The following is a description of a gene set: Human Gene Set: HEB_Q6 Genes having at least one occurrence of the motif RCCWGCTG in the regions spanning 4 kb centered on their transcription starting sites. This matches the TCF12 transcription factor binding site V$HEB_Q6 (v7.4 TRANSFAC). species: Homo sapiens, and this is the list of marker genes: USP2, RTN3, COLEC12, RGS7, WNT6, CCDC26, NUDT18, DVL3, BTF3P11, SPMIP5, MRPL54, IMPG1, FBRS, MYO18A, SLC1A4, ZP1, MYH3 (myosin heavy chain 3), PRRG2, ALK, XCL2, CARMIL3, CDK5R2, RASSF8, LMOD1, TBX6, HOOK1, ACVR1, H3C3, KDM2A, TMEM184A, ACTB, HMGN2, SH3BP1, EFNA1, S100A8, RUNX1T1, GPR37L1, CNTN2, GFI1, XPNPEP1, H2BC7, AAK1, TGFB2, PGF, SPECC1, GAS7, NTNG2, ZSWIM8 (zinc finger SWIM-type containing 8), WNT2B, CYTH3, CDC42SE1 (CDC42 small effector 1), MAPK4, RIPOR1, DAAM1, SRP54, FMO5, HOXA3 (NCBI Gene Id 3200), WDR81, SMAD7, OR10J1, SYTL2, RARA, PSD, FNDC5, TRIM8, FBXL20, CACNB3, APBA3, GADD45G, VSTM2A, GRIN2B, DTX1, ARHGEF5, FBXO5, ITSN1, TSC22D4, RNF121, SLC30A1, PLXNB3, KLHDC8A, CMKLR2, ZNF593, MUSK, RTKN, PDZK1, YTHDF2, ELN, KCNH3, KCNS3 (NCBI Gene Id 3790), TNS1 (NCBI Gene Id 7145), AGBL5, CREB3L1, TMOD4, RCOR2, GABPB2, ADAMTS8, KCNJ2, TGFB3, GNB3, ITGB1BP2, L1CAM, ZNF646, MLLT11, CCDC65, FAM98A, SORBS1, ANGPTL2, PTPN7, CYP2F1, MOB3C, KCNH2, RIN1, EPN3, TRAF4, NFE2L1, VEGFA, KNCN, KIRREL2, ADGRB3, CBFA2T2, PAX1, CADPS, CLVS1, DHRS3, PRKAG1, TMEM255A, NANOS1, ACTG2, ANXA8, GPR62, PMP22, KLF13, TNNT2, GPD1, HOXC12, TLNRD1, IL34, H3C4, MED13, SUMO2, C1orf210, ANGEL1, RPL4, RUFY1, TBC1D10B, ZNF668, CCND2 (cyclin D2), PRR30, NR5A1, TRIP4, SRPX, NDST4, S100A2 (S100 calcium binding protein A2), PDGFB, CHID1, RBMS3, SPOCK2, ATXN7L2, H2BC3, RXRG, RASL12, POLL, TUBA4A, KLK13, SEMA7A, SEZ6, MIR137HG, UBTF, MEN1 (NCBI Gene Id 4221), PRMT6, BCL6, RAB3A, MIR22HG (MIR22 host gene), GRIK3, TPPP3, ASTN1, KLHL10, MKNK2, BRD4, MRGPRF, ERBB3, CATSPER2, RNF111, PSME3, COL16A1, PDK2, ZNF362, NOSIP, SUV39H2, GATA3, HOXC4 (homeobox C4), CSMD3, MIR9-1HG, FAAP100, TLE3, SYNC, RASGEF1A, INKA1, EN1, BAZ2A, SPMIP8, INF2, GPR162, DOK3, LINC01089, ZRANB1, KCNMB3, TRIM46, RAB1B, UBE2D3, TUBA4B, NUTF2, FITM1, DLG2, ZNF398, CLEC14A, PPP2R3A, ZNF385A, ABHD4, IGF1, ADGRL3, TFAP4, ST6GALNAC5, HID1, RTL9, NT5C3B, MAN1A1, KSR2, TRAPPC3, SVIL, TEFM, CTXN1, ARHGEF2, CACNB2, SLC1A7, GREB1L, VN1R3, SPATS1, MLIP, CELF3, DOCK6, BCL2L2, MYLK, USP1, RNF213, KCNQ5, SYT6, DPCD, HSD11B1, UFM1, MACF1, PRKCB, GOLPH3L, HPCA, TRPC4, RORC, CBFA2T3, CKM, SOX5, GRIN2D, SOBP, ORAI3, RAPGEFL1, ZMIZ1, NOL4, MDK, NDST2, H2AC7